The following is a description of a gene set: Human Gene Set: KEGG_MEDICUS_ENV_FACTOR_PHIP_TO_DNA_ADDUCTS PhIP to DNA adducts. Pathway ID: N01371. Pathway type: Env factor. Pathway class: nt06250 DNA adduct formation. studied in species Homo sapiens Pathway Definition from KEGG: PhIP -- CYP1A2 >> SULT1A -> N-sulfonyloxy-PhIP == DNA, and this is the list of marker genes: CYP1A2, SULT1A1, SULT1A3, SULT1A4, SULT1A2